Given this list of marker genes GAS6, STAT5A, EPO (NCBI Gene Id 82670), ITPKB, FCER1G (Fc epsilon receptor Ig), BCL2 (BCL2 apoptosis regulator), APOH, GATA1, SELENOS, NOD2, KITLG, CCL5, STAT5B, MIF, SNAI2, MAEA, CCR5, MIRLET7B, GHSR (NCBI Gene Id 92434), IRF7, CLEC5A, here is a description of the gene set: Human Gene Set: GOBP_NEGATIVE_REGULATION_OF_MYELOID_CELL_APOPTOTIC_PROCESS studied in species Homo sapiens Any process that stops, prevents, or reduces the frequency, rate, or extent of a myeloid cell apoptotic process.